The following is a description of a gene set: Human Gene Set: GOBP_REGULATION_OF_POTASSIUM_ION_TRANSPORT studied in species Homo sapiens Any process that modulates the frequency, rate or extent of the directed movement of potassium ions (K+) into, out of or within a cell, or between cells, by means of some agent such as a transporter or pore., and this is the list of marker genes: ATF4, KCNIP4, MIR29B1, KCNC1, KCNAB3, KCNE2, KCNIP1, NOS3, HTR2A, KIF5B, MIR26A1, DPP6, RGS4, DLG1, ACTN2, GRP (NCBI Gene Id 2922), PRNP, CAV3, GALR2, WNK4, ADORA1, DRD2 (dopamine receptor D2), ATP1B2, EDN3, NPPA, FHL1, KEL (NCBI Gene Id 3792), SUMO1, KCNE3, ANO6 (NCBI Gene Id 196527), MIR212, NOS1, KCNC2, KCNRG, KCNQ1, ANK2 (ankyrin 2), MIR30D (NCBI Gene Id 407033), VAMP2, KCNS1, CD63, KCNG1, ABCC8, GNB2, YWHAE, TREM2, OXSR1, MIR21, ANK3, KCNH2, NOS1AP, KCNE5, LRRC26, AMIGO1, LRRC55, ATP1B3, KCNAB1, KCNG3, NEDD4L, KCNIP2, STK39, KCNG2, KCNS2, NEDD4, WWP2, CAB39, KCNF1, KCNIP3, PTK2B, KCNG4, HCRT, DRD3 (dopamine receptor D3), KCNAB2, KCNJ2, GCK, KCNE1, KCNN4, ATP1B1, AKAP7, DRD1, FLNA, CAV1, OPRK1, CACNA1D, DPP10, LRRC38, GAL, ABCC9, ADRA2A, KCNN2, AKAP6, CASQ2, BIN1, MIR103A1, LRRC52, KCNS3